The following is a description of a gene set: studied in species Mus musculus Any process that modulates the frequency, rate or extent of postsynaptic density organization. Mouse Gene Set: GOBP_REGULATION_OF_POSTSYNAPTIC_DENSITY_ORGANIZATION, and this is the list of marker genes: Il1rap, Ptk2b, Lrrc4b (leucine rich repeat containing 4B), Fgfr1, Lrrtm1, Slc30a1, Ptprs, Abi3, Lats1, Nrxn1, Cdh2, Lrrtm2, Zmynd8, Sipa1l1, Cfl1, Cbln1, Prickle2, Ptprd, Lrfn1 (NCBI Gene Id 80749), Caskin1 (CASK interacting protein 1), Cript, Dbn1, Lrfn4, Grid2, Prickle1, Nlgn1, Abi3bp